The following is a description of a gene set: Genes predicted to be targets of miRBase v22 microRNA mmu_miR_717 in miRDB v6.0 with MirTarget v4 prediction scores > 80 (high confidence targets). from publication Chen Y, Wang X (PMID 31504780) species: Mus musculus Mouse Gene Set: MIR_717, and this is the list of marker genes: Arc, Clcc1, Tafa2, Gtf2a1, Sult1e1, Lad1, Zfp704, Pgap1, Rcan2, Flvcr1, Pgm2l1, Dop1a, Dedd, D630045J12Rik, Hoxd13, Acyp2, Pcnx4, Sntb2, Zdhhc17, Picalm (phosphatidylinositol binding clathrin assembly protein), Cracr2b, Cry2, Syp, Zfand6, Mab21l1, Reps2, Fut10, Prss23, Top2b, Car10, Bcl7b, Gm4791, Kdm5a, Phf3, Spry1, Csnk1g3, Usp49, Nsg2, Abcd2, Cyb561d1, Tor1aip2, Birc3, Ddi2, Cdv3, Dnajb9, Rnf144b, Ywhae, Rap2c, Rundc3b (RUN domain containing 3B), Gucy2c, Stk24, Ets2, Cdc42, Mecp2, Osbpl6, Nxph1, Kdm7a, Jam3, Lce3d, Tmod3, Fundc1, Tasp1, Zfp423, Yars1, Dach1, Nedd9, Cyfip1, Tmem134, Rbfox3, Ints14, Bend3, Enc1, Trmt10b (NCBI Gene Id 69934), Terf2, Dnajc6, Me3, Ttc8, Gtf2h5, Tmem30b, Foxc1, Ndp, Hspe1, Elf1, Ankrd46, 4921524J17Rik, Eno2, Tpbpa, Tbl1xr1, Tsc22d1, Cnot1, Tmod2, Nlgn1, Zmat2, Rnf182, Ggh, Spata1, Casq2, Ak4, Tdpoz8, Slc6a19os, Zfp712, Ncoa7, Ptprz1, Epha4, Tyro3, Evi2a, Setd5, Basp1, Pten, Rps6kb1, Lce3b, Prrc2b, Zfp449, Calb1, Pcdh19, Pja1, Acp3, Dpp10, Igsf1, Zfp735, Popdc2, Hnrnpd, Myo5b, Atp11a